The following is a description of a gene set: Human Gene Set: WP_DISORDERS_OF_NAD_METABOLISM studied in species Homo sapiens Disorders of NAD metabolism, and this is the list of marker genes: NADSYN1, CD38, NAXE (NAD(P)HX epimerase), BST1, NAXD